The following is a description of a gene set: Human Gene Set: HP_ABNORMAL_HAMATE_BONE_MORPHOLOGY species: Homo sapiens A structural anomaly of the hamate bone, which is the ulnar-most bone located within the distal row of carpal bones, neighboured by the capitate bone radially. Abnormal hamate bone morphology, and this is the list of marker genes: EVC, FGFR3, EVC2, FLNB, GLI1, PRKACA, PRKACB, SMOC1, ATP7A, FLNA, BPNT2, DYNC2LI1